Given this list of marker genes SLC25A5, VDAC2, CACNA1F, CACNA1D, CACNA1S, APP, VDAC1, VDAC3, MCU, SLC25A4, CYCS, SLC25A31, CACNA1C, SLC25A6, here is a description of the gene set: studied in species Homo sapiens Mutation-caused aberrant Abeta to VGCC-Ca2+ -apoptotic pathway. Pathway ID: N01004. Pathway type: Variant. Pathway class: nt06460 Alzheimer disease. Human Gene Set: KEGG_MEDICUS_VARIANT_MUTATION_CAUSED_ABERRANT_ABETA_TO_VGCC_CA2_APOPTOTIC_PATHWAY_N01004 Pathway Definition from KEGG: APP* -> Abeta -> VGCC(L-type) -> Ca2+ -- MCU -> Ca2+(mito) -- MPTP -> CYCS